The following is a description of a gene set: Human Gene Set: GOBP_REGULATION_OF_STEM_CELL_DIFFERENTIATION studied in species Homo sapiens Any process that modulates the frequency, rate or extent of stem cell differentiation., and this is the list of marker genes: N4BP2L2, EIF2AK2, LTBP3, SP7, SMYD5, SOX6, OCIAD1, HES1 (NCBI Gene Id 3280), TEAD2 (TEA domain transcription factor 2), FOXC1, MTA2, NR5A2, NKX2-5, KDM3A, PUS7, FGF2, CDK12, DHX36, RBBP7, ZFP36L2, KAT5, SOX17, HES5, PRKDC, KDM4C, TACSTD2, MIR302B, GATAD2B, YTHDF2, NOTCH1, YAP1, TCF15, TRIM6, ESRRB, PWP1, NELFB, TGFBR2, LBH, TGFB2, BMPR1A, CHD3 (NCBI Gene Id 1107), WNT3, CDK13, NUDT21, SIRT6, SLC4A11, NSUN2, GSK3B, MIR372, TBX3, MTA1, HDAC2, ITCH, SETD1A, HNRNPU, PTN, TMSB4X, PRICKLE1, STAT3, RBM24, HDAC1, MIR146A, CDK6, MBD3, JAG1, PDGFRA, NFE2L2, HSPA9, CHD4, TBX5, SOX9, OSM, FZD1, EZH2, MTA3, GATAD2A, MTCH2, METTL3, REST, GDNF, SOX5, ABL1, BBS12, HOXB4, NR6A1, RBBP4